The following is a description of a gene set: Human Gene Set: CALVET_IRINOTECAN_SENSITIVE_VS_RESISTANT_UP species: Homo sapiens from publication Calvet L, Geoerger B, Regairaz M, Opolon P, Machet L, Morizet J, Joseph JM, Elie N, Vassal G (PMID 16501609) In vivo neuroblastoma (NB) xenograft model, resistant to the DNA-topoisomerase I inhibitor irinotecan (CPT-11), has been established to study resistance mechanisms acquired in a therapeutic setting. Common mechanisms of resistance were not involved in this resistance. Thus, we compared the gene expression profiles of sensitive, resistant, and reverted tumors using cDNA expression arrays. Expression of selected transcripts was confirmed by quantitative real-time PCR. We found that pleiotrophin (PTN), a heparin-binding growth factor, was the only gene significantly affected: PTN gene expression was downregulated in all resistant tumors (8-14-fold) as compared to sensitive tumors, and was increased (2-4-fold) in all reverted tumors as compared to resistant tumors. PTN thus appeared to be a likely candidate gene associated with resistance to CPT-11 in this in vivo model. To investigate the direct implication of PTN in NB, we transfected two NB cell lines with RNA interferences in order to silence PTN. PTN failed to demonstrate implication in resistance to CPT-11 in vitro but could influence sensitivity to CPT-11 exclusively through an in vivo mechanism. Indeed, vasculature was significantly enhanced in resistant NB xenografts compared to sensitive and reverted xenografts, and we suggest that PTN is acting in our resistant in vivo NB model as an angiostatic factor. Genes up-regulated in neuroblastoma xenografts: sensitive vs resistant to the topoisomerase inhibitor irinotecan., and this is the list of marker genes: PTN, CD40LG, ATM, RFC2, FLT1